The following is a description of a gene set: Human Gene Set: WP_ESTROGEN_SIGNALING Estrogen signaling species: Homo sapiens, and this is the list of marker genes: MAPK9, FOS, IKBKB, NFKB1, AKT1, PRKACA (protein kinase cAMP-activated catalytic subunit alpha), CREB1, MAPK14, IKBKG, BRAF, GNGT1, JUN, GPER1, PIK3CA (phosphatidylinositol-4,5-bisphosphate 3-kinase catalytic subunit alpha), GNAS, GNB1, SP1, BCL2, MAP2K1, ELK1, CHUK, MAPK1, ESR1